The following is a description of a gene set: Mouse Gene Set: GOBP_NOTOCHORD_DEVELOPMENT The process whose specific outcome is the progression of the notochord over time, from its formation to the mature structure. The notochord is a mesoderm-derived structure located ventral of the developing nerve cord. In vertebrates, the notochord serves as a core around which other mesodermal cells form the vertebrae. In the most primitive chordates, which lack vertebrae, the notochord persists as a substitute for a vertebral column. species: Mus musculus, and this is the list of marker genes: Tead1, Gli1, Nog, Wnt5a, Wnt11, T2, T, Epha2, Cobl, Id3, Sox9, Col2a1, Gdf3, Stil, Crb2, Ppp1r35, Kdm6a, Nckap1, Noto, Gli2, Yap1, Tead2, Efna1